Given this list of marker genes Snx29, Hmg20a, Dars1, Fhip2a, Derl1, here is a description of the gene set: Mouse Gene Set: CUI_CDC2_TRAIL_RESPONSE_UP Genes positively differentially expressed in cell type: cDC2 (conventional dendritic cell type 2) upon treatment with cytokine: TRAIL in mouse lymph nodes in vivo. studied in species Mus musculus from publication Cui A, Huang T, Li S, Ma A, Pérez JL, Sander C, Keskin DB, Wu CJ, Fraenkel E, Hacohen N (PMID 38057668) Cytokines mediate cell-cell communication in the immune system and represent important therapeutic targets. A myriad of studies have highlighted their central role in immune function, yet we lack a global view of the cellular responses of each immune cell type to each cytokine. To address this gap, the authors created the Immune Dictionary, a compendium of single-cell transcriptomic profiles of more than 17 immune cell types in response to each of 86 cytokines (>1,400 cytokine-cell type combinations) in mouse lymph nodes in vivo. A cytokine-centric view of the dictionary revealed that most cytokines induce highly cell-type-specific responses. For example, the inflammatory cytokine interleukin-1β induces distinct gene programmes in almost every cell type. A cell-type-centric view of the dictionary identified more than 66 cytokine-driven cellular polarization states across immune cell types, including previously uncharacterized states such as an interleukin-18-induced polyfunctional natural killer cell state.